The following is a description of a gene set: A process that is carried out at the cellular level which results in the assembly, arrangement of constituent parts, or disassembly of an endoplasmic reticulum membrane. studied in species Mus musculus Mouse Gene Set: GOBP_ENDOPLASMIC_RETICULUM_MEMBRANE_ORGANIZATION, and this is the list of marker genes: Trdn, Arl6ip1, Atl1, Lpcat3, Atl2, Steep1, Vapb, Tmed2, Stx18, Rtn4, Bnip1, Reep5, Vcpip1